The following is a description of a gene set: species: Homo sapiens Any process that occur in response to the presence of critically short or damaged telomeres. Human Gene Set: GOBP_TELOMERE_MAINTENANCE_IN_RESPONSE_TO_DNA_DAMAGE, and this is the list of marker genes: ERCC4 (NCBI Gene Id 7509), INO80, RUVBL2, TFPT, XRCC1, DCLRE1B, RTEL1, MCRS1, APEX1, UCHL5, TERF2IP, TERF2, RIF1, ACTL6A, ACD, NBN, SHLD1, INO80D, RUVBL1, INO80E, SHLD3, MAD2L2, TFIP11, ERCC1, INO80B, CDK2, ACTR8, INO80C, NFRKB, YY1, PPP1CA, SHLD2, ACTR5